Given this list of marker genes Ctdp1, G6pd2, Tbx18, Pdgfra, Pitx2, Slc25a4, Calr (NCBI Gene Id 12317), T, Tsc1, Trip10, Hnrnpu, Adprhl1, Fhod3, Hamp, Bves, Mir208a, Rxra, Rbpj, Wt1, Asb2, Met, Tcap, Cacybp, Acadm, Atg7, Pdgfrb, Atg5, Gata6, Fdps, Nrg1, Sox6, Kcnj8 (NCBI Gene Id 16523), Myocd, Xirp1, Parp2, Adra1b, Irx3, Agt, Pax3, Hdac3, Actc1, Myod1, Ep300 (NCBI Gene Id 328572), Foxp1, Alpk3 (alpha-kinase 3), Yy1, Lrrc10, Alpk2, Sik1, Mtor, Zmpste24, Myh10, Large1, Tomm70a, Camk2d, Nox4, Mef2c, Lmna, Plec, Ctcf, Rbm10, Dkk1, Bmpr1a, AW551984, G6pdx, Actn2, Bvht, Zfp418, Ang2, Pak1, Srf, Arid1a, Ppara, Frs2, Csrp3, Myo18b (myosin XVIIIb), Fhl2, Adrb1, Cavin4, 3425401B19Rik, Prox1, Nr3c1, Igf1, Rgs2, Meis1 (NCBI Gene Id 353058), Sgcd, Tbx5, Rarb, Dyrk1a, Nkx2-5, Naglu, Itgb1, Cby1, Ttn, Tgfb1, Ccn4, Pdlim5, Ift88, Gata4, Mesp1, Mylk2, Smad4, Myh11, Rara, Hand2, Mef2a, Kat2a, Gsk3b, Cripto, Map2k4, Ift20, Wnt3a, Cdk1, Efnb2, Pin1rt1, Acvr1, Hey2, Slc9a1, Dicer1, Sorbs2, Prkg1, Ccnd2, Hdac2, Greb1l (growth regulation by estrogen in breast cancer-like), Pi16, Nrap, Tbx3, Popdc2, Shox2, Bmp2, Gsk3a, Nkx2-6, Cav3, Sirt6, Isl1, Pin1, Dll1, Cxadr, Vegfa, Bmp10, Hamp2, Slc8a1 (NCBI Gene Id 319418), Rgs4, Myh6, Grem1, Fzd7, Bmp4, Akap6, Edn1, Sgcb, Neb, Myl2, Prickle1 (prickle planar cell polarity protein 1), Ddx39b, Kdm6b, Maml1, Mylk3, Rxrb, Col14a1, Akap13, Arrb2, Adra1a, Sirt1, Agtr2, Speg, Nebl, here is a description of the gene set: species: Mus musculus Mouse Gene Set: GOBP_CARDIAC_MUSCLE_CELL_DIFFERENTIATION The process in which a cardiac muscle precursor cell acquires specialized features of a cardiac muscle cell. Cardiac muscle cells are striated muscle cells that are responsible for heart contraction.